The following is a description of a gene set: from publication He P, Lim K, Sun D, Pett JP, Jeng Q, Polanski K, Dong Z, Bolt L, Richardson L, Mamanova L, Dabrowska M, Wilbrey-Clark A, Madissoon E, Tuong ZK, Dann E, Suo C, Goh I, Yoshida M, Nikolić MZ, Janes SM, He X, Barker RA, Teichmann SA, Marioni JC, Meyer KB, Rawlins EL (PMID 36493756) TM4SF4+ PENK+ neuron species: Homo sapiens Human Gene Set: HE_LIM_SUN_FETAL_LUNG_C7_TM4SF4_POS_PENK_POS_NEURON_CELL, and this is the list of marker genes: LINGO2, ELAVL2, RYR2, MTUS1, PTGER3, GATA3, DIRAS2, PLPP4, ZCCHC12, ZFHX2, CDK5R2, DNER, SEMA4F, RND2, VSTM2L, ENHO, DLGAP1, CASTOR2, PTPRG, MAPT, TG, AKR1C2, GRIA3, RADIL, PPP2R5B, HTR3A, SLC2A1, MAB21L2, OGDHL, POU2F2, TM4SF4, SLC1A6, BBC3, ISLR2, GLCCI1, SLC5A7, PTGFR, MIR7-3HG, ZFR2, RGS7, SCN2A, KCNQ5, YPEL4, GCHFR, PIANP, ISL1, ELMO1, VASH2, SCML4, DNM3, GPRC5B, TMOD1, GNB5, NOS1AP, DUSP26, PNMA6A, BAIAP2, DPP6, PLPPR5, RAB6B, GRM8, PRSS3 (NCBI Gene Id 86247), ARL4C, ERC2, CHST1, CLCN4, SLC18A3, SPINT2, MARCHF1, EPS8L1 (NCBI Gene Id 54869), TTC9B, RFTN1, EFNA3, GPR22, SORL1, ACTL6B, FAM241B, TMEM130, DTNA, REM2, SH2D3C, ICA1, B3GNT4, HMGCLL1, ARHGEF28, DPF1, CELF4, SLC38A1, NTNG1, CELF5, VSTM2A, ENTPD3, TSHZ3, SYT5, SLC35G2, MPP3, CARMIL2, ST7 (NCBI Gene Id 93655), GPR137C, REEP1, PLD5, PIRT, TMEM200C, TAC3, RASA4B, SH3GL2, AKR1C1 (aldo-keto reductase family 1 member C1), HRK, SYNPO2, FSTL5, SAMD14, TOX2, MPP2, PAK3, HOXB5, SCN3A, NALF1 (NCBI Gene Id 731895), PENK, SMIM18, SEZ6L, PNMA2, AMER2